Given this list of marker genes MAP2K2, MAPK9 (mitogen-activated protein kinase 9), FOXO3, MAP2K5, JAK2, PDPK1, EIF4EBP1, RPS6KA5, GRB2 (NCBI Gene Id 80715), NCAM1, PIK3R2, KCNN2, EGR2, GRIA3, NSF, IRS1, NCF1, BMP2, SHC3, BCL2L11, APC, NTF3, TRAF6, CREB1, MAPK8 (NCBI Gene Id 5599), HRAS, GSK3B, RHOG, SQSTM1, KCNA3, SORT1, NFATC4, ADAM17, CAMK4, AKT1, ACACB, RELA, MAPK1, CYFIP1, NCK2, MAP2K1, RAB3A, PTK2B, MAP3K1, PTPN11, SPP1, EIF4E, MAPT, NTRK3, CAMK1 (NCBI Gene Id 8536), EIF2S1, DLG1, NGFR, NCF2, CTNNB1, PRKAA2, STAT3, SH2B2, CDC42, GRIP1, PIK3R1, RPS6KA3, GRIA2, NFKBIA, MAPK10, ALPL, PTPRF, MTOR, NFKB1, GRIA1, CFL1, MEF2A, DOK5, NCK1, SIRPA, RASGRF1, JUN, MAP3K2, TSC2, SHC4, CDK5, RAP1A (NCBI Gene Id 5906), YBX1, CASP3, IGF2BP1, GABRB3, MAPK14, STAT5A, VAV3, EGR1, CRTC1 (NCBI Gene Id 94159), IRS2, GRIN2B, STAT5B, EIF2S2, RACK1, IKBKB, RPS6KA1, MARCKS, RAF1, PRKCD, RPS6KB1, RAC1, CHUK, TIAM1, KSR1, LINGO1, SRC, MEF2C (NCBI Gene Id 4208), CSNK2A1, RANBP9, CDK5R1, NTRK2, IKBKG, CNR1, VAV2, SH2B1, STAT1, BAD, EEF2, DOCK3, SHC2, MAPK3, NTRK1, SHC1, FOS, MAPK7, NGF, CDKL5, FYN, CAMK2A, ELK1, SYN1, FRS2, BDNF, FRS3, PRKAA1, PLCG1, PPP2CA, GRIN1, CDH2, DPYSL2, RPS6, KIDINS220, here is a description of the gene set: Human Gene Set: WP_BRAINDERIVED_NEUROTROPHIC_FACTOR_BDNF_SIGNALING Brain-derived neurotrophic factor (BDNF) signaling studied in species Homo sapiens